The following is a description of a gene set: species: Homo sapiens mouse primary BMDCs were stimulated with tlr ligands and gene expression changes were profiled on Affymetrix arrays Human Gene Set: GSE17721_CTRL_VS_GARDIQUIMOD_8H_BMDC_UP Genes up-regulated in comparison of control dendritic cells (DC) at 8 h versus those stimulated with Gardiquimod (TLR7 agonist) at 8 h. from publication Amit I, Garber M, Chevrier N, Leite AP, Donner Y, Eisenhaure T, Guttman M, Grenier JK, Li W, Zuk O, Schubert LA, Birditt B, Shay T, Goren A, Zhang X, Smith Z, Deering R, McDonald RC, Cabili M, Bernstein BE, Rinn JL, Meissner A, Root DE, Hacohen N, Regev A (PMID 19729616), and this is the list of marker genes: CCNE1, SAP30BP (NCBI Gene Id 29115), ALDH3A2, RFC1, NSMF, NQO2, UBXN1, MRPL49, TOPBP1, CENPQ, MRPS26, POLD4, AKR1B10, LDLRAP1, SRR, ENC1, FRRS1, RASSF5, PRKCD, DAP, NDST1, HEBP1, FAM91A1, IMP3, CHMP3, STARD4, AMACR, NDUFV3, CDK2, SLC39A11, PPP1R17, SPTBN1, LGALS4, PES1, FERRY3, CYP51A1, TNFRSF21, CMYA5, ADK (adenosine kinase), SMARCD2, CCNB2, HDAC5, ERLIN1, PPP1R14B, PHETA2, SPRY2, POGLUT2, TSPAN13, BLOC1S5, C1QBP, SLC46A3, CD48, PNKD, EPS15, C2CD2L, FAM193B, NAT9 (NCBI Gene Id 26151), FAM50A, PRXL2A, SMPD2, RPS26, TAF9, RP9, RETREG1, ZMPSTE24, H2AX, HTATIP2, TEC, PCNA, KIF20A, RPS8, N4BP2L1, BPGM, DHX16, SAR1B, CLEC6A, RPS6KB2, SMC3, IQSEC1, TM9SF2, OCSTAMP, IKZF2, ZNF524, MRC1, TF, CENPH, PCYOX1, ATP5IF1, MRPS15, MTCH2, NUP35, OGFOD2, TRIM41, YPEL1, KLHL22, PNRC1, KCNN4, WDR45, CROT, PRDX3 (peroxiredoxin 3), SLC7A7, CHCHD7, FUCA2, CDH1, ELMO2, CPT1A (carnitine palmitoyltransferase 1A), OPN3, TECR, MAP4K4, EPRS1, LRRC1, WBP11, CDK16, RAD51, CDC25B, SH3BGRL3, CCDC28A, PARP16, SOCS6, EBP, TGFBI, BTBD1, ZFAND2A, MKNK2, KIAA1143, LANCL1 (NCBI Gene Id 10314), ZFYVE19, MCOLN1, ANKRD28, ANLN, TALDO1, BPHL, MRPL42, MAP2K6, BRCC3, RGL2, DDT, P2RX4, NAXE, BSG, PYGB, SLC25A13, CIITA, TSPAN14, NFAM1, ATP5PF, MRPS24, FAM167B, PSAPL1, ZNRD2, ALDH1L1, PLSCR3, MBP, FBF1 (NCBI Gene Id 85302), NIT1, BRD8, GNE, HAUS8, TADA1, DHX36, GADD45G, DHCR24, CCNA2, ZBTB14, DUSP19, ACOT8 (acyl-CoA thioesterase 8), GLCCI1, PARK7, MRPL48, DPCD, GALC, ELF3, HNRNPA2B1, PTS, MRPL11, QTRT1, CEP19, ACADS, FAU, MINDY1, GSTZ1, ABTB1, AKR7A2, ASGR2, SNX14, ALOX15B, RDH14, METTL18, MRPL23, RAP1A, NDUFA4, ZBTB11-AS1, UFSP2, DOK3, QRSL1, MRPL19, LCLAT1, ACO2, KLHL9, MTARC2